The following is a description of a gene set: studied in species Homo sapiens Genes containing one or more binding sites for (MPHOSPH8) in their promoter regions (TSS -1000,+100 bp) as identified by GTRD version 20.06 ChIP-seq harmonization. Human Gene Set: MPHOSPH8_TARGET_GENES from publication Yevshin I, Sharipov R, Kolmykov S, Kondrakhin Y, Kolpakov F (PMID 30445619), and this is the list of marker genes: LINC01623, LINC02100, LINC02453, DCP1B (NCBI Gene Id 196513), HERC6, ZNF200, BBC3, ZNF530, TAP2, RPS27L